Given this list of marker genes Rcan3, Unc13a, Dcdc2a, Dysf, Hsp90ab1, Nedd1, Ctnna1 (NCBI Gene Id 66546), Nexn (NCBI Gene Id 99513), Tmod4, Traf3ip1, Lsp1, Marcksl1, Myo16, Myoz3, Parva, Spata31, Smtn, Kif1a, Phf6, Katnb1, Ccdc61, Cyfip1, Ndn, Clstn1, Espn (NCBI Gene Id 56226), Rmdn3, Nav3, Lrrk2, Myo1f, Myh4, Rita1, Agbl1, Lmo7, Lrpprc, Haus4, Ttll12, Pdlim3, Kcna2 (potassium voltage-gated channel, shaker-related subfamily, member 2), Ttll7, Htt, Cep295, Ccdc88a, Tagln2, Wipf3, Epb41l4a, Ftcd, Arfgef2, Eps8l1, Dlgap5, Baiap2l1, Kif13a, Sbds, Mprip (NCBI Gene Id 97684), Abra, Map1b, Stau2, Fez1, Myh7 (myosin, heavy polypeptide 7, cardiac muscle, beta), Dnai7, Klhl2, Ssna1 (NCBI Gene Id 98824), Haus6, Dnm2, Actn3, Dcx, Slc4a1, P4hb, Unc5c, Apoe, Klhl3, Apc2, Kif1b, Clasp1, Slc26a5, Arpc5l, Fbxo25, Eps8l3, Myh14, Pstpip2, Hnrnpk, Pafah1b1, Ofd1, Kpnb1, Mylk2, Ptk2, Vps41, Inf2, Mtss2, Gapdhrt, Dlg4, Mapk8, Tnnt3 (troponin T3, skeletal, fast), Spaca9, Tor1a, Tor1b, Spata6l (spermatogenesis associated 6 like), Aif1l, Bccip, Zfp207, Hook1, Wasf1, Cald1, Snap25, Map7d2, Gas7, Nf2, Dyrk1a, Tnnt2, Golga2 (golgin A2), Myh11, Adora2a, Rhag, Gtse1, Nkd2, Shroom2, Syn1, Nin, Mid1, Limd2, Misp, Ccdc88b, Tor1aip1, Krt2, Coro1b, Haus8, Terf1, Reep1, Ang4, Tmsb10, Kifbp, Nos3, Ccdc187 (NCBI Gene Id 329366), Avil, Cfap157, Bicd1, Actn4 (actinin alpha 4), Nfkb1, Arpc3, Arpc4, Lyn, Myl9, Abi3bp, Dmd, Larp6, Magi1 (membrane associated guanylate kinase, WW and PDZ domain containing 1), Hspa2, Ssh1, Tmod1, Cacna1d, Kif13b, Diaph1, Map9, B9d2, Spmip6, Gbp2b, Samd14, Ddx3x, Fmn1, Agbl4, Snx5, Csrp1, Ccr5, Anxa8, Ang, Agbl2, Arl4c, Mapre2, Sptbn2, Eml1, Trim32, Gnas, Ppp2r2a, Prickle4, Kif20b, Sptan1, Vamp2, Myh6, Myo19, Smtnl1, Gabarap, Kif23, Slc6a2 (NCBI Gene Id 20538), Kif2b, Vill, Ipp, Tns4, Wasf3, Abcg2, Myot, Mx2, Ttll5, Gnb3, Myoc, Rala, Tnnc2, Jakmip1, Whamm, Dnal1, Ccser2, Spata4, Panx1, Ace (NCBI Gene Id 11421), Pdlim7, Katnal1, Crmp1, Kif9, Fam161a, Hdac6, Trak2, Shank3, Sgk1, Eml4, Rhcg, Reep4, Gsk3b, Mapre1, Nlrp5, Actn2, Cnn1, Arpc1b, Tnni3, Dusp3, Dpysl3, Myo1g, Ttll13, Nme1, Dmtn, Stim1, Rab10, Gas2 (growth arrest specific 2), Fus, Kif19a, Akap1, Mark2, Wdr90, Ccsap, Magi2, Lmod3, Micall2, Sptbn4, B4galt1, Ska2, Kif28, Rcc2, Ppp5c, Ang2, Myo1b, Clasp2 (CLIP associating protein 2), Syne1, Tppp3 (NCBI Gene Id 67971), Kif3c, Actc1, Myo1e, Rtcb, Syt11, Gbp2, Prkce, Hnrnpu, Capn6, Bmp10, Ptprc, Nde1, Spire1, Rgs2, Tnnt1, Ceacam1, Myo1h, Kif5c, Apc, Dip2b, Map1a, Shroom4, Ermn, Mefv, Togaram2, Bbs4, Dlg5, Capza1b, Tppp2, Vapb, Tln2, Fblim1, Phactr1, Actr3b, Cep57, Arhgef7, Tbce, Cep350, Cacnb2, Prnp, Tprn, Myrip, Calm3, Vcl, Map3k1, Gli1, Hpca, Katnbl1, Ankrd23 (ankyrin repeat domain 23), Palld, Iqschfp, Nherf1, Spag5, Kif5b, Gc, Kifc2, Myo10, Dclk2, Bag2, Capza2, Pparg, Fscn2, Axl, Knstrn, Ino80, Llgl1, Sncb, Arc, Ankrd1, Map1lc3a, Coro2b, Wdr1, Adcy8 (adenylate cyclase 8), Myo3b, Smad2, Ndrg1, Flnc, Tbcc, Wipf1, Coro6, Cobll1, Pdlim5, S100a4, Dstn, Arhgef2, Ssh2, Mrtfa, Tagln3, Hap1, Myo7b, Gipc1, Reep3, Tnnc1, Tmsb4x, Klc4, Neil2, Aldoa, Myo5b, Myh7b, Ctnna3, Cav3, Sorbs3, Abitram, Trim54, Git1, Myh3, Haus7, Krt10, Ranbp10, Rab27a, Spef1l, Plekhh2, Frg1, Cep135, Ank2, Clip1, Kif11, Fmr1, Clip2, Macf1, Rab11fip5, Arfgef1, Hook2, Cap1, Spatc1, Snca, Ppp1r9a, Stk38l, Scnn1a, Aldoc, Ank3, Nusap1, Myh10, Nos2, Ankrd24, Rps3, Klhl17, Ssh3, Plk1, Hdgf, Pdlim1, Smc3, Tbc1d21, Alkbh4, Msrb1 (methionine sulfoxide reductase B1), Cap2, Rab8a, Cnn2, Eml6, Neb, Nebl, Myh8, Spag8, Svil (supervillin), Lin7c, Tmsb15a, Clmn, Knl1, Pfn1, Mapk8ip2, Ablim1, Pfn2, Tmsb15l, Ttll6, Kif12, Calml4, Camsap3, Klc1, Apbb1, Fhl3, Clxn, Prkn, Nrcam, Hcls1, Ophn1, Sntb1, Camsap2, Dbn1, Clip3, Aldob, Strbp, Afdn, Flii, Sptb, Fgf13, Fhod3 (NCBI Gene Id 269001), Cdh1, Mapre3, Rp1, Cct5, Msrb2, Trpv4, Rho, Rab14, Pdcd5-ps, Ywhah, Tpm3-rs7, Triobp, Tpm1, Fsd1, Smad4, Tubgcp3, Ush1g, Trim46, Pacrg, Ift88, Cdk5, Mid2, Anln, Pacsin3, Map7d3, Fxyd1, Syne3, Slc6a4, Brca2, Kif14, Map1lc3b, Ap1g1, Pde4b, Fgd4, Fyn, Kif3b, Emd, Pawr, Gmfb, Diaph3, Gapdhrt2, Rab11a, Pls1, Vezt (NCBI Gene Id 215008), Phactr3, Itgb1, Akap5, Rab6a, Msn, Dnase1, Kptn, Katna1, Coro1c, Fmnl3, Tmod3, Kif16b, Pycard, Lasp1, Enkd1, Calm1, Kif22, Tmod2, Cobl, Ttbk1, Map1s, Rhbg, Kbtbd13, Med28, Crk, Ogg1, Marcks, Hook3, Vash1 (vasohibin 1), Mdm1, Fxyd5, Mylip (myosin regulatory light chain interacting protein), Fam107a, Egfr, Ang5, Dlec1, Actb, Vapa, Dlc1, Was, Bloc1s6, Fkbp15, Impact, Atp1a1, Rara, Gnb1, Atcay, Rab25, Ctnnal1, Llgl2, Gphn (gephyrin), Mapk8ip1, Antxr1, Arhgef10, Rhoa, Fmnl2, Hip1, Cd2ap, Mical1, Numa1, Mast1, Twf2, Appbp2, Adgrv1, Mical2, Spag6l, Gas2l1, Nf1, Tmem67, Tppp, Syne2, Ywhag, Prc1, Stmn2, Map2, Gabarapl1, Hspb7, Adss1, Capn2, Tpm4 (NCBI Gene Id 72202), Myo1d, Trim36, Epb41, Chp1, Capn10, Lima1, Cacybp, Rusc1, Fhdc1, Aif1, Myh13, Ang6 (angiogenin, ribonuclease A family, member 6), Fabp3, Polb, Cxcr4, Tpgs1, Pde6g, Kifc3, Arpc1a (NCBI Gene Id 80673), Epb41l3, Trpm7, Psrc1, Abraxas1, Xirp1, Trim2, Rab3c, Spef1, Sgip1, Evl (NCBI Gene Id 14026), Sncg, Svbp, Prom1 (prominin 1), Cacna1c, Kifap3, Rab3d, Stxbp5, Vps16, Synpo, Arpc2, Pfn5, Fmnl1, Synpo2, Add1, Trak1 (NCBI Gene Id 67095), Obscn, Capg, Farp1, Actr3, Ppargc1a, Mark4, Frmd5, Gas2l3, Coro1a, Irag2, Kif26b, Utrn, Fam83d (NCBI Gene Id 99445), Pacsin2 (protein kinase C and casein kinase substrate in neurons 2), Cgn, Dag1, Twf1, Kif21a, Kif15, Limch1, Myoz1, Shroom3, Myo7a, Arpc5, Dst, D1Pas1, Bcl2l11, Vinac1, Kctd6, Snta1, Mtss1, Stxbp5l, Ap1ar, Tom1, Mib2, Synpo2l, Vbp1, Afap1, Sptbn1, Mtus1, Rab3a, Disc1, Rab39b, Iqgap3, Rab6b, Kif3a, Sntb2, Tnni2, Spag6, Add3, Kifc1, Tlnrd1, Epb41l5 (erythrocyte membrane protein band 4.1 like 5), Mybpc2, Pdlim2, Mybpc1, Gria1, Cimap3, Ptpn4, Dctn2, Daam2, Crocc, Scin, Tmsb15b2, Phactr4, Efhc1, Spc24, Cfl1, Ankrd2, Spata32, Dync1i1, Bin1, Kcnma1, Ajuba, Csrp3, Myl4, Wipf2, Rmdn2, Ccdc88c, Trim63, Katnal2, Kif18b, Ift81, Tln1, Trpc6, Sipa1l1, Arl8b, Cnn3, Tbcd, Kif21b, Ccdc69, Map4k4, Add2, Picalm, Cdk5r1, Taok1, Rai14, Eps8, Eml2, Lrrc61, Aqp2, Rmdn1, Klhl1, Rela, Kcna5, Mast2, Gcsam, Kif24, Pkd2l1, Cep290, Birc5, Capza3, Myo5a, Tubgcp2, Reep2 (receptor accessory protein 2), Epb41l4b, Spta1, Kcnq2, Ampd1, Fbxw11, Kif20a, Dpysl4, Fscn3, Pex14, Rad51d, Rgs14, Pdcd5, Pof1b, Ush2a, Cenpe, Cryab, Map6, Map6d1, Pdlim4, Sag, Myo9b, Ccdc66, Lmod2, Tnni1, Ablim3, Cttnbp2, Bicd2, Ptprn, Kif1c, Cnga3, Npc1l1, Kifc5b, Phactr2, Bicdl1, Drg1, Ckap5, Epb41l2, Nphs1, Ccdc181, Myl2, Bcas3, Tcap, Fscn1, Daxx, Frmd3, Myo5c, Cetn3, Gja6, Synm, Ptpn3, Kif7, Mlph, Eef2, Myo15a, Eml5, Gapdh, Rflna, Plekhm2, Kif19b, Shroom1, Jmy, Mypn, Prune1, Tubgcp6 (tubulin, gamma complex component 6), Ceacam2, Capza1, Togaram1, Krit1, Pick1, Myh2, Ldb3, S100a6, Myo18b, Abraxas2, Dnm1, Map4, Dnm1l, Luzp1, Ttll4, Ptprt, Clip4, Rab3b, Kirrel1, Saxo2, Ktn1 (NCBI Gene Id 16709), Arl3, Calm2 (calmodulin 2), Ift74, Hsp90aa1, Camsap1, Flnb, Map10, Dixdc1, Myo18a (NCBI Gene Id 360013), Myh9, Klc3, Mylk, Myo6, Espnl, Fam110c, Alms1, Rdx, Fkbp4, Eml3, Ska3, Abi3, Vil1, Inppl1, Ttll11, Nrap, Hsph1, Nme8, Mapt, Pxn, Mtcl1, Kif2a, Stard9, Ttll9, Washc1 (WASH complex subunit 1), Spire2, Spag9, Tbcb, Kif4, Fermt2 (NCBI Gene Id 218952), Klc2, Rflnb, Myoz2, Bex6, Pfn3, Hdgfl3, Dlg1, Vasp, Gria2, Daam1, Cript, Setd2, Ppp1r42, Brsk1, Vash2, Lims1, Diaph2, Spata6, Epb41l1, Pkd2 (NCBI Gene Id 77380), Gsn, S100b, Wasf2, Sntg2, Lcp1, Clu, Xirp2, Tmsb15b1, Flna, Tbcel, Ezr, Maco1, Ppp1r9b, Ppp2ca (protein phosphatase 2 (formerly 2A), catalytic subunit, alpha isoform), Gja1, Gas2l2, Cep57l1, Ctnna2, Iqgap1, Tiam1, Ndc80, Vps18, Kif5a, Pstpip1, Plekhg3, Fhod1, Pls3, Fmn2, Lrp8 (NCBI Gene Id 16975), Uxt, Kif26a, Agbl5, Stmn4, Kif2c, Kcne1, Farp2, Fnta, Rcsd1, Ush1c, Enah, Eps8l2, Ank1, Agbl3, Nod2, Phpt1, Homer2, Capn1, Maea, Cfap144, Parvg, Ppp1r18 (NCBI Gene Id 76448), Racgap1, Sybu, Ttll2, Tmem201, Mapk8ip3, Cdk5rap2, Opa1, Ttll1 (NCBI Gene Id 319953), Klhl20, Rab29, Fes, Lmod1, Cenpj, Pfn4, Wasl, Enc1, Cdk5r2, Rab11b, Lrrc10, Anxa2, Slc8a1 (NCBI Gene Id 319418), Tpr, Mrtfb, Tpm2, Cotl1, Dnm3, Pxk, Uaca, Nup62, Trpc5, Stmn1, Nuf2, Stmn3, Kcnj11, Cttn, Tpm3, Aatf, Scn5a, Ndel1 (nudE neurodevelopment protein 1 like 1), Capn3, Abl1, Ttbk2, Ska1, Cltc, Myl3 (myosin, light polypeptide 3), Myo1c, Dctn1, Setd3, Csrp2, Fermt1, Camk2d, Cfl2, Trappc14, Mtus2, Myh15, Kif18a, Dbnl, Kif17, Mical3, Actn1, Myh1, Kif6, Actr2 (actin related protein 2), Ncald, Cetn2, Mybpc3, Gjb6, Iqgap2, Tubgcp4, Myo1a, Des, Plec, Myo9a, Sptbn5, Cetn1, Kif27, Sntg1, Bex4, Agtpbp1, Jakmip3, Stx1a, Tbca, Saxo1, Ablim2, Itprid2, Ccdc170, Kcnn2, Lmtk2, Shtn1, Coro7, Pacsin1, Cep44 (NCBI Gene Id 71256), Snx6, Cep70, Myo3a, Gas8, Amotl2, Hip1r, Myl12b, Coro2a, Rab27b, Appl1, Adnp, Tulp1, Atf5, Capzb, Bloc1s2 (NCBI Gene Id 73689), Pknox2, Ttn, Tubgcp5, Gmfg, Parvb, Pak1, Tns1, Nek6, Dcp1a, Spast, Kcnc1, here is a description of the gene set: Binding to a protein component of a cytoskeleton (actin, microtubule, or intermediate filament cytoskeleton). Mouse Gene Set: GOMF_CYTOSKELETAL_PROTEIN_BINDING species: Mus musculus